The following is a description of a gene set: Human Gene Set: GOBP_NEGATIVE_REGULATION_OF_EXTRACELLULAR_MATRIX_ASSEMBLY Any process that stops, prevents or reduces the frequency, rate or extent of extracellular matrix assembly. species: Homo sapiens, and this is the list of marker genes: TGFBR3, MIR18A, PPARG, MIR145, MIR98, MIR19A, MIR9-1, MIR27B (microRNA 27b), MIR483, MIR19B1, ANTXR1, MIR29B1